Given this list of marker genes LRP8, SEL1L3, RRAGD, TGFBR1, GADD45A (NCBI Gene Id 1647), RAI2, ATG14, PTP4A1, ERBIN, EIF4E2, AKAP1, CD2AP, TNRC6C (NCBI Gene Id 57690), BPTF, HPRT1, LRRTM2, WEE1, CNOT7, SPART, BAG5, ACBD3, RAP2C, TRPC3, ESR1, RALGPS2, EPS15, VPS13D, EPC2, ERP44, PEX5L, NABP1, FOSL1, BLCAP, DLG5, PRKD3, TGFBR2, RAB5A, EMX2, HOXA3, DPYSL2 (NCBI Gene Id 1808), AKAP11, ASXL2, AKIRIN2, CBX6, ACSL4, PIP4P2, IL15, MECP2, CLIP1, JARID2, AGO1, SPTY2D1, WDR20, RUNX3, POP7, FIBIN, MB21D2, SERBP1, TSC1, BTG1, PAK6, LY75, FMR1, SNIP1, ST18, SHANK2, MBD2, ST8SIA5, PRUNE2, CLCN5, CGGBP1, PSAP, TANC2, PHF12, KCNA4, SAMTOR, MDM4, MMGT1, PCNX1, KRTAP26-1, LONRF3, MYBL1, RAD51B, MLLT6, CBFB, TSHZ1, ZBTB4, MPHOSPH9, NHLH2, SFMBT1, ZEB2, RTCA, LDAF1, SPHK2, PLAA, UBB, TES, ZNF609, CBLB, CAMSAP2, LGALSL, BTBD7, FMC1, SKIDA1, NACC2, SALL3, G0S2, HEG1, CHST1, PPARG (peroxisome proliferator activated receptor gamma), ITPRIPL2, IRF1, ARHGEF4, DAAM1, ATP12A, PXYLP1, HS3ST5, DCAF8, NCKAP5, FSD1L, LRIG1, MEMO1, ENPP5, PRKAA1, LCORL, MFSD6, IL1RAP, THOP1, SULF1, FYN, EGLN3, RNF38, ZBTB18, CPEB3, FAT3, PLCB1, ZBTB20, IMPDH1, POU4F1, DCBLD2, ABHD3, DLL1, PTPRG, HIVEP2, DYNLL2, WNK1, CENPO, TMEM50B, SRSF2, ABRAXAS2, LRP12, VCF1, PDZD11, ANKIB1, CCDC126, HOXD1, WDR47, IGF1, WDR33, EREG, BTAF1 (B-TFIID TATA-box binding protein associated factor 1), RASD1, MIGA1, BTBD3, USP28, BAHD1, ELK3 (ETS transcription factor ELK3), PIGA, APPL1, ADCY1, PDIK1L, NFIB, FASTK, CHD5, SMOC1, DNAL1, ZFYVE26, CDS1, TAFA1, DICER1, PIK3CB, ARL6IP1, FOXF2, DNAJC16, GAREM1 (GRB2 associated regulator of MAPK1 subtype 1), MBNL1, SLC44A1, NEUROG1, FBXO48, SYT6, SBF2, CLTC (NCBI Gene Id 9511), UBE3B, MAP3K20, OTUD3, CALM2, BMPR2, TLCD3A (NCBI Gene Id 79850), SPEN, RACGAP1, USP33, AGO4, ATG16L1, EDN1, FRMD6, DDX6, CASD1, PHF20, CCNY, RBM25, SLC2A4RG, SERINC3, PIKFYVE, ABCC5, INO80, UBA3, TMEM250, ZNF800, ZNF217, CUL3 (cullin 3), ARHGAP1, POU3F2, UBE2W, CRACD, DGKE, CPEB1, BTF3L4, LDLRAD4, EBF3, ZMAT3, SZRD1, PAN3, C2orf15, SBNO1, INSIG1, G3BP2, TMOD1, PURG, AGFG1, ACSL1, ARHGEF26 (Rho guanine nucleotide exchange factor 26), MDFIC, THSD7A, HECA, ABCB7, DENND4C, NALF1, SOCS5, NECTIN3, NFIA, RTN1, CSMD1, USP8, SMARCD2, ZNF594, SAR1B, VGLL4, FBXO28, ZFYVE9, BRWD1, PTPN4, KIF13A, FSTL5, CCDC6, JMY, ARHGAP21, RAPGEF4, KBTBD8, BHLHE41, ZNF107, MAP3K12, MIGA2, PGM2L1, DLC1, CDK19, PXK, TFCP2L1, AR, RPS6KA5, FUT9, PSD, TET3, TENT2 (NCBI Gene Id 167153), GTF2H1, RNF145, DYNC1LI2, SLMAP, SCUBE3, DCUN1D3, VPS37A, CAPRIN2, PPP1R15B, STX6, NPAT, FZD6, DSG1, FERMT2, UBE2D2, SOS2 (NCBI Gene Id 96829), NPEPL1, MACIR, PIK3C2A, TBL1XR1, PPFIA2, LDLR, ITPR1, YTHDF2, MSMO1, AAK1 (AP2 associated kinase 1), FRZB, DSEL, LPGAT1, SECISBP2L, MAPK1 (NCBI Gene Id 5594), EOGT, STIM2 (stromal interaction molecule 2), SLAIN1, R3HDM1, CBY1, LMLN, SPATA2, RAB12, CLCN3, CYP2U1, CD69, HSPA8, KDM2A, MTCL1, APCDD1, LSMEM1, MBNL3, WDFY3, MIER1, SH3D19, NRBF2 (nuclear receptor binding factor 2), SAMD8, ADAM12, BRWD3, CFL2, ARAP2, PHACTR2, PPP6R2, SNX2, MTMR10, ACVR1, RFX7, ERCC4, SNX31, ING2, CNOT6, ATP6V1B2, MET, SLC6A6, NSD3, SYBU, ARHGAP12, PHF14, NPNT, ACBD5, MAF, PMEPA1, SPOCK1, RNF216, CNOT4, SIX4, ZNF862, USP13, ITGB8, LRP6, RBBP8, STON2, RO60, JADE1, TRIM2, SNX5 (NCBI Gene Id 27131), TOGARAM1, CYSLTR1, KMT2C, MCTP1, PHAF1, KIAA1191, DOCK3, DENND10, MID1IP1, UBXN2B, CEP170, DIAPH3, GJA1, BMP3, LRP2, ROBO2, HECW2, KLF7, TEX2, HCFC2, ULK2, OSBPL6, here is a description of the gene set: Genes predicted to be targets of miRBase v22 microRNA hsa-miR-301a-3p in miRDB v6.0 with MirTarget v4 prediction scores > 80 (high confidence targets). from publication Chen Y, Wang X (PMID 31504780) studied in species Homo sapiens Human Gene Set: MIR301A_3P